Given this list of marker genes ZNF124, GLCCI1, SLC35A5, XPR1 (xenotropic and polytropic retrovirus receptor 1), MCEE, CDC25B, CYP4F3, RBBP7, NUF2, SOCS6 (suppressor of cytokine signaling 6), ACOT13, MYCL, TMEM47, FAM32A, ATP5MG, SVIL, TRMT1, TDRD3, CCNA2, PRDX3, AAAS (aladin WD repeat nucleoporin), ITM2B, WWC2, FIS1, F8A1, GOLM1, DGAT1, VDR, OSBPL11, PDE2A, MANBA, ANKRD10, HIGD2A, CENPF, DUT, GALC, GNPDA1, LENEP, ECHDC1, SLC38A10, PARK7, TFB2M, CHCHD7, HNRNPF, NME7, IL6ST, TMEM51, TOPBP1, ZYG11B, ATP6V0B, ELMO2, CETN2, MCM7, ANKH, TFRC, MLLT10, RBBP4, TMEM19, TGFBR1, ADISSP, PANK1, PRSS44P, ADK, MDH1, PLEKHG2, WDPCP, SIRT3, YEATS4, MTA3 (NCBI Gene Id 731342), CREBRF, MRPL48, EEPD1, YWHAZ, HM13, RPL12, SERINC3, DIO1, TNRC6B, POLDIP3, VPS37A, CXCR4, CLEC6A (C-type lectin domain containing 6A), DYNLT1, TF, APCDD1, NFATC2IP, CCDC28A, SLC29A3, FRAT2, TAS2R1, CCNQ, AACS, PRPH, CEP164, GABARAP, DPH7, SFXN3, PARD6A, TRIM3, UBR1, MGST2, RAC1, TM9SF3, COG6, SCD, BSG, LZTR1, ANLN, UPF3B, SUPT4H1 (NCBI Gene Id 6827), GAB3, TBC1D23, CCAR2, RAD1, RPS3, VIPAS39, N4BP3 (NEDD4 binding protein 3), SSBP2, ALDH1L1, ABCC3, XPOT, NDRG4, NDUFB3, METTL8, HELZ, QRSL1, ERMP1, MDP1, CTNNA1, ADGRA3, LAPTM4B, CCNI, HHEX, RNF181, ODF1, MRPS26, CPT1A, PBX2, HLX, MAZ (MYC associated zinc finger protein), ATP5F1A, PLXNB2, NDUFA13, EHHADH, PAG1, MIDN, HDAC6, GPR87, GALK2, GHRL, SLC37A3, PIK3C2A, NCAPH, ZNF277, DBR1, PACS2 (NCBI Gene Id 23241), PNPLA7, TFEC, HAUS4, MTRES1, HEPACAM2, CIDEB, FRYL, AAMDC, SYNJ2 (NCBI Gene Id 8871), TIMM10B, KITLG, MAP2K6, TXN2, TECPR1, CENPA, FDPS (farnesyl diphosphate synthase), MKNK2, LTBP3, LIMA1, MIGA2, NDUFB2, LIPA, UBE4B, VDAC1 (voltage dependent anion channel 1), CEP85, ACAT1, POLR3GL (NCBI Gene Id 84265), PEPD, NDUFA11, FKBP4, SPATA4, RGL2, RNF5, MAPK3, ATM, MRPL11, CLIC1, ELOVL6, PCNA, GALT (galactose-1-phosphate uridylyltransferase), C1D, RPS3A, ERBB3, IMPA2, here is a description of the gene set: Genes up-regulated in comparison of control dendritic cells (DC) at 12 h versus those stimulated with CpG DNA (TLR9 agonist) at 12 h. mouse primary BMDCs were stimulated with tlr ligands and gene expression changes were profiled on Affymetrix arrays from publication Amit I, Garber M, Chevrier N, Leite AP, Donner Y, Eisenhaure T, Guttman M, Grenier JK, Li W, Zuk O, Schubert LA, Birditt B, Shay T, Goren A, Zhang X, Smith Z, Deering R, McDonald RC, Cabili M, Bernstein BE, Rinn JL, Meissner A, Root DE, Hacohen N, Regev A (PMID 19729616) species: Homo sapiens Human Gene Set: GSE17721_CTRL_VS_CPG_12H_BMDC_UP